Given this list of marker genes NRP1, DLL1, ACVR1, NR2F2, PDPN, PROX1, RBPJ, HOXA13, here is a description of the gene set: studied in species Homo sapiens The commitment of a cell to an endothelial cell fate and its capacity to differentiate into an endothelial cell. Human Gene Set: GOBP_ENDOTHELIAL_CELL_FATE_COMMITMENT